Given this list of marker genes GFM1, JUP, HYKK, DDX23, STX10, RNH1, UQCC5, TMEM87A, TRMT1L, TMEM106C, NBR1, CCDC115, ZDHHC6, LRP6, ITGB8, EIF2B5-DT, MPND, PRR11 (NCBI Gene Id 55771), CIPC, CNOT7, TXLNA, MED8, CCDC125, DPM2, CDK13, HEMK1, CANX, NEIL1, GOT2, USP54, MIR4512, NUP88, H2AC6, POLR3A, KBTBD6-DT, VPS52, PROCR, RAG1, H2AC25, MGRN1, EIF2S1, HUS1, CSTF1, TYW5, RPS21, RPL3, RPS15, CRAMP1, RPS18, CHMP3, MSL2, PARK7, HSD11B1L, CHD2, GABPB1-AS1, CALR3, TPGS1, CDK4, MYG1, TNFSF9, SPRYD4, UBE2B, THRAP3, CDC6, CIMIP5, ATP6V1D (ATPase H+ transporting V1 subunit D), STOML2, ID2-AS1 (NCBI Gene Id 101929606), SELENOI, RNF14, UNC5B-AS1, UNC45A, XRCC2, ARF6, RPRD2, PYROXD1, TFPT, AP3B1, IMP4, TMX1, UFM1, TTC23L-AS1 (TTC23L antisense RNA 1), PCNX4-DT, LENG8 (NCBI Gene Id 79162), SH2D6, ERCC1, EPRS1, IER5, WBP2, RIC8B, AMD1, NCOA2, TTC33, PPIL2, MTHFR, TIPIN, TMEM222, VPS26B, RPL7L1P8, DNAJB12, GPBP1, EIF2B5, MIR762HG, NDUFS6, TMA16, HYPK, MIRLET7IHG, C19orf38, ZFP91-CNTF, ZC3H10 (zinc finger CCCH-type containing 10), LGMN, FAM228B (family with sequence similarity 228 member B), MCM7 (NCBI Gene Id 4176), IFT140, ARRDC4, SAE1, MVB12A, PAN2, H2AZ2, TPI1P2, SF3B6, ENSG00000275765, ZNF397, ZSCAN22, TLDC2, ODAD1, CLIP1, HEATR5B, PLOD3, PHB1, EMC1-AS1, KLHL7, DNAI4, STX5-DT, GLI1, RHEBL1, FXR2, RBM22, RBBP4, EXOC8, DDX39A, G3BP1, MIR320A (NCBI Gene Id 407037), ACAT2, CUTC, SLC37A1, MRPL18, HSP90B1, CETN3, ENO1-AS1, WDTC1-DT, RTN4, SEC22C, RPS20, TMEM179B, ORMDL1, ZYX, NSMCE3, SLC12A9, COX19, PRR7, MIR638, SKA2, FAM131B-AS2, MIA3, RNU2-17P, MYORG, ISG20L2, MIGA2, C19orf44, ARIH2, DOCK9-DT, ZFP2, ANKRD13D (ankyrin repeat domain 13D), YWHAQ, SWT1, C2orf49-DT, ERCC5, DLEU2 (NCBI Gene Id 8847), ZDHHC5, IQCD, ZNF687, TBC1D22A, MED23, EEF1A1, HMGB3P22, UGGT1, DERL1, NUP35, NPM1, RPP14, ZNF689, TUBB, JPT1, TRNAU1AP, RNF34, DNM2, RAD51, MRTFA, MRPL13, CDKL3, NUP37, KAT5, ZWILCH, RPL36, KCTD21, CHCHD3, TMEM14C, FBXL17, STIL, APBB3, WDR3, GTF2H4, TYK2, CERT1, TOMM40, IQGAP1, GANC, WDR36, GDAP2, PNRC2, TARS2, TRA2A, MRPL35, ENDOV, EXOC6B, CENPBD2P, FOSB, PRR4, PABPN1, SAMD4B, IFT52 (NCBI Gene Id 51098), SLC35A3 (solute carrier family 35 member A3), BANF1, CDK12, ZMAT5, TPCN1, ANKRD24, ZHX1-C8orf76, ANO6, MRPS23, RAD1, MICOS13, CARS2, SRSF10 (NCBI Gene Id 89048), LENG8-AS1, PPP5C, SLC25A42, C1orf43, NARS1, KCNIP2, PRPF31, EFCAB5, NUP93-DT, RNF123, STK19, TFAP2A (transcription factor AP-2 alpha), PPP2R1A, LPXN, GPR108, LARP4, PMS1, TMED1, LUC7L2, ADPRM, ZNF490, RBIS, ZNF687-AS1, MON1A, SYNGR4, CDC20-DT, PMF1-BGLAP, PDE4A, ANP32E, SRCAP, EOLA2-DT, ADGRF3, MLLT3, PTPDC1, RPS16, NCAPD3, CYP20A1, PPP1R13L, CUL5, PRKCI, S100PBP, WEE2-AS1, CDIN1, UBE2Q1, SLC35B4, C1orf216, PARPBP, PLGRKT, YJU2, SP2-AS1, ZNF202, ENPP3, TMEM177, KLHL26, MST1, RPS9, ZFP91, SRD5A3-AS1, IQCH-AS1, AHNAK, LINC02427, COQ6, ZNF774, MRPS27, ZNF2, IER2, AGAP2-AS1, TTC23L, CERNA3, ZNF791, MRPS15, STAP2, VAMP1, AZI2, VCPIP1, WDR89, MTERF4, C9orf85, IK, OSBPL3, SNAPC5, MPV17L2, VTI1A (vesicle transport through interaction with t-SNAREs 1A), CAST, POLR3G, TOM1L2, ATG4C, FBRS, SP8, NSA2, ZSCAN29, TNPO1, YARS1, LTBR, KLHL20, AP1G2, ENSG00000227218, TBC1D22A-DT, CTDP1, DCAF6, STK10, MSMP, TTC5, FAHD1, TAF6L, C6orf226, BRPF1, KMT2B, MRPS31P4, ERCC6L2-AS1, GABPB1, GTPBP3, HOMER1, PCNX4, DOCK9, TCP1, CHMP7, ENSG00000255647, METTL25B, ZHX1, RNF32-DT, MIR22HG, UBE2D2, WDR81, ZNF501, TMEM165, PPP2CA, LTA4H, SLC25A3, COQ10B, PLBD1, GOT1, RPAIN, PPAN-P2RY11, ZNRD2, GATAD2A, SH3D19, UQCR10, MRPL52, PPAN, CENPJ, H2BC26, KBTBD6, BLOC1S2, TRIP10, SFXN5, UBAP2L, STAT1 (NCBI Gene Id 6772), RNU6-92P, MTBP, STAT6, SSBP1, TARDBP, ATP8B1, ATP5IF1, TBK1, SZT2, ARL5A, DCUN1D4, MIRLET7I, AURKA, HEBP1, FTSJ3, KLHL7-DT (KLHL7 divergent transcript), SIRT6, SNORD43, POLK (NCBI Gene Id 51426), GOLGA5, RTRAF, DXO, PIDD1, LPCAT3, MPC2 (mitochondrial pyruvate carrier 2), PSMD3, IARS1, TMEM143, ZNRD2-DT, SPG21, MIR3912, DNMT1, HMGXB3, SCAMP2, RBM39, CAB39L, SUPT5H, HTD2, ZNF23, POC1A, POP7, AHCYL1, VMAC (NCBI Gene Id 400673), ESYT1, FUCA2, RAD51C, SNHG17, PPM1G, LINC03064, POC5, BRIX1, CSNK1A1, ERCC6L2, TNPO3, DRC3, C5orf15, SERINC4, TNFAIP8, DYRK2, TRAF6, SNORD54, CA13, SGO2, RN7SKP134, COX15, SLC52A3, CLSTN1, SLC35A4, PBX1, CNOT3, HNF4G, HAGH, ETF1, GOT1-DT, LYSMD3 (LysM domain containing 3), CXXC1, AP4M1, CCND2, N6AMT1, RPS21-DT, LAMP1, AKTIP, NCL, PSMC5, CCT8, ILF3-DT, VARS2, NAGK, ZNF184 (zinc finger protein 184), BBS2, TXN2, TUBGCP4, GFM2, ZNF514, LZTS2, MPV17, PPP1R12B, ILF3, LASP1, TTC41P, HNRNPL, WASF2, C2orf49, AATF (apoptosis antagonizing transcription factor), SETDB2, ZC3H4, DDX46, H2AZ2-DT, TRDMT1, SPRTN, ATF7IP, SLC7A7, STX12, VPS37A, LIAS, TBC1D2, STT3B, IFT70A, PPP1R18, CDKN3, UNG, RPLP2, PNPO, UBE2W, PSMD12, ID2, INTS12, PTPN4, MIR4519, IL23A, ZNHIT1, EOLA2, ENSG00000272195 (NCBI Gene Id 101928068), NUP42, RPS3A, ZCWPW2, COQ8A, PER1, ZBTB8OS, IWS1, EIF1AD, USP35, HTR7P1, NDUFA11, PTCD3, SPNS1 (NCBI Gene Id 83985), MZF1, MOSPD3, PPP1R21, PSMA5, PGGT1B, DNAJC9-AS1, MCTP2, PPP1R21-DT, UBR4, NR4A2, DOLPP1, BLCAP, RPL9, CDC20, GSTCD, POLR3D, NAGA, PRMT9, SLC25A35, ENO1, NDUFA2, DNAJC16, WDTC1, RPL4, BAG6, H2BC4, ABHD17B, AKAP8L, LZTFL1, RRM2, H4C5, HSD17B4, CLCN6, ATXN2L, WBP1L, FEM1B, TMEM18, FBXW11, NOP53, PCGF1, ZNF77, FNTB, ARHGEF37, PMF1, C15orf61, RSPH1, USP42, SLC12A9-AS1, MBLAC2, MRPL36, CAPG, ANAPC5, CASP9, ATAD2B (NCBI Gene Id 54454), MAIP1, PPP2CA-DT, LINC02960, RNF213-AS1 (RNF213 antisense RNA 1), FEM1A, RSPH1-DT, TEX14, ELL3, PRH1, CHD1 (NCBI Gene Id 1105), EEF1AKMT1, H2AX, RALA, here is a description of the gene set: from publication Yevshin I, Sharipov R, Kolmykov S, Kondrakhin Y, Kolpakov F (PMID 30445619) Genes containing one or more binding sites for (HES4) in their promoter regions (TSS -1000,+100 bp) as identified by GTRD version 20.06 ChIP-seq harmonization. species: Homo sapiens Human Gene Set: HES4_TARGET_GENES